Given this list of marker genes EDEM1, MANEA, MAN1B1, EDEM2, MAN1A2, MAN2B2, MAN2B1, MAN1A1, MAN1C1, MANEAL, MAN2C1, MAN2A1, MANBA, EDEM3 (NCBI Gene Id 87240), MAN2A2, here is a description of the gene set: Catalysis of the hydrolysis of mannosyl compounds, substances containing a group derived from a cyclic form of mannose or a mannose derivative. Human Gene Set: GOMF_MANNOSIDASE_ACTIVITY studied in species Homo sapiens